Given this list of marker genes Prkx, Dab2ip, Cdh2, Ablim1, Bach2, Pou3f1, Morf4l2 (mortality factor 4 like 2, NCBI Gene Id 71961), Minar1, Apc, Sall4, Cfap58, Umps, Pou2f2, Tenm4, Fbxl22, Kynu (NCBI Gene Id 70789), Lin7a, Cdh4, Rbms3, Zfp704, Dlk1, Odf2l, Tent5a (terminal nucleotidyltransferase 5A), Kif26a, Vps26a, Inip, Rab10, Slbp, Hlcs, Cxxc4, Capzb, Rps6ka5, Mindy2, Bclaf3, Kdm2a, Larp1, Ppm1h, Gngt1, Fmr1, Foxp2, Tent4b, Arhgef10l, Tnpo1, Tiparp, Klf9, Unc5d, Hoxb1, Tmprss15, Fryl, Aard, Taok3, Itih2, Hook3, Zfp385b, Actr3, Sh3bgrl, Cntn4, Gfra2, Sh3kbp1, Xpo7, Cbx4, Mecp2, Zfhx3, Chmp2b, Glyr1, Pdzrn4, Fos, Nkain2, Trp53inp1, Glcci1, Camta1, Jade1, Nr2c2, Iffo2, Rfx3, Inpp4b, Ap3b1, Ago3, Eml4, Cadm2, Fgf18, Elavl4, Bend7 (NCBI Gene Id 73743), Xpr1, Cfap410, Aspn, Ern2, Mrgprb1 (MAS-related GPR, member B1), Vps13a, Rims2, Kmt2a, Grik2, Mtf1, Sox14, Atp13a2, Fcgr3, Tmem255a, Adam10, Larp4, Cdc42ep3, Sobp, Ing3, Jag1, Nfic, Fbxw7 (F-box and WD-40 domain protein 7), Sp3, Slc7a10, Lig4 (NCBI Gene Id 319583), Dnajc13, Atosa, Atxn7, Itga6, Unk, Lmna, Stox2, Tti2, Kcna1, Zfp281, Gbp7, Nus1, Dsg2, Nbeal1, Naa15, Tox, Pax2, Kmt5a, Slc17a6, Runx1, Tial1, Nufip2, Zmat2, Mex3a, Bptf, Cacng2, Hic2, Map3k13, Fut9 (NCBI Gene Id 14348), Scn8a, Zbtb10, Cbx7, Npepps, Tshz1, Ets1, Nfib, Ube2k, Zfp641, Zswim6, Mfap3l, Gnaq, Onecut2, Sox2 (SRY (sex determining region Y)-box 2), Nrxn1, Dusp10, Ahdc1 (AT hook, DNA binding motif, containing 1), Anks1b, Tcf4, Nalf1, Ctbp2, Camk4, Ptp4a1, Zfp93, Ywhab, Gapt, Sox4, Ptges3, Sel1l, Slc16a6, Dmrta2, Ext1, Cdyl2, Mast4, Rell1, Vcp, Jarid2, Casz1, Dpp10, Mbnl1, Cfap53, Lrch2, Ythdf1, Nipbl, Ugcg, Elfn2, Mrpl19, Cacnb4, Runx1t1, Pbx1, Duoxa1, Tmem245 (transmembrane protein 245, NCBI Gene Id 319762), Bicd1, Nemf, Sec14l1, Agap1, Hapln1, Prdm5, Mettl9, Hoxc10, Egfr, Oxr1, Sun2, Gmeb1, Nudt4, Arid1b, Phf21a, Ckap4, Mettl2, Rps6kb1, Shisa9, Otx1, Txn1, Fanci, Rbfox1, Med13l, Uba6, Slc39a8, Uncx, Zfp36l1, Homer1, Lrrc4, Plppr4, Mapre1, Vegfc, Celf2, Lrrc4c, Sacm1l, Rnf6, Ppp3ca, Myrip, Tmeff2, Tomm40, Pcdh8, Nrg2, Nphp3, Tnrc6a, Add3, Zbtb20, Dennd10, Pax6, Znrf1, Fndc5, Plagl2 (pleiomorphic adenoma gene-like 2), Gm527, Dtna, Satb1, Ccr1, Grm5, Scai, Pcdh7, Mrgprx2, Rbms1, Fbxo30 (NCBI Gene Id 71865), Sbk1, Ndst3, Eif4g3, Spink10, Zbtb4, Gsk3b, Yipf6, Ccdc43, Rbpms, Mmp19, Cnot7, Pmepa1, Actn1, Tmtc4, Tbx3, here is a description of the gene set: Mouse Gene Set: MIR_129_5P from publication Chen Y, Wang X (PMID 31504780) Genes predicted to be targets of miRBase v22 microRNA mmu_miR_129_5p in miRDB v6.0 with MirTarget v4 prediction scores > 80 (high confidence targets). species: Mus musculus